Given this list of marker genes Slc27a2, Phyh, Slc25a17, Hacl1, Pecr, Aldh3a2 (aldehyde dehydrogenase family 3, subfamily A2), here is a description of the gene set: species: Mus musculus Alpha-oxidation of phytanate Mouse Gene Set: REACTOME_ALPHA_OXIDATION_OF_PHYTANATE